Given this list of marker genes Agfg1, Fshr, Tnp2, Nectin2, Selenof, Mfsd14a, Cfap61 (NCBI Gene Id 99460), Ift88 (NCBI Gene Id 21821), Brdt, H2bc1, Chd5, Prm1, Kat5, Kdm3a (NCBI Gene Id 73570), Tsga8, H2al2a, Gopc, Sycp1 (synaptonemal complex protein 1), Epc1, Rnf8, Dmrtc2, Tnp1, Pygo1, Tmf1, Psme4, Agfg2, Tbpl1, Hmgb2, H1f7, Pygo2, Tssk6, Sycp3, Gm773, Piwil1, here is a description of the gene set: The specialization of the spermatid nucleus during the development of a spermatid into a mature male gamete competent for fertilization. species: Mus musculus Mouse Gene Set: GOBP_SPERMATID_NUCLEUS_DIFFERENTIATION